The following is a description of a gene set: Using whole-genome Affymetrix microarrays (HG-U133A), we characterized the transcriptome profile of cultured human macrophages stimulated for 4 h with interleukin 1 (IL-1) or interleukin 6 (IL-6). We found that, in distinction to liver cells, IL-1 is much more potent than IL-6 in modifying macrophage gene expression, although considerable heterogeneity in response of macrophages deriving from individual blood donors was observed. The obtained results permitted to identify a large number of cytokine-responsive genes. coding for proteins of unknown function that are now being studied in our laboratory. They may represent novel targets in the anti-inflammatory therapy. Genes up-regulated in comparison of untreated macrophages versus those treated with IL1 and IL6. species: Homo sapiens from publication Jura J, Wegrzyn P, Korostyński M, Guzik K, Oczko-Wojciechowska M, Jarzab M, Kowalska M, Piechota M, Przewłocki R, Koj A (PMID 18498781) Human Gene Set: GSE8515_IL1_VS_IL6_4H_STIM_MAC_UP, and this is the list of marker genes: IGFBP3, TMEM268, TMC7, ZHX2, CFP, EN2, BID, SNN, TNIP1, PDE4B, ARL2BP, PPAT, MLH1, F2, MARCKSL1, SEPTIN6, RNF115, RFTN1, AGT, LARP4B, TOR3A, TNK1, CD80, MAU2, SERPINB2 (serpin family B member 2), VAV1, PIM2, DOCK9, RNGTT, IK, MED7, TP53BP2, B4GALT6, TSSK2, CCSER2, DENND5A, SLC2A6, VPS4A, CXCL8, ASAP2, P2RY10, CD70, IL1B, PAFAH1B2, SEC61G, UTP14A, PKIG, EGR3, P2RX7, STAT4, MAGEB3, NPY4R, BCL10, GYS2, RENBP, KDM6B, CXCL2, RIPK2, ST3GAL4, SIK3, CCR7, ZNF586, NECAP2, PSEN1, STX11, CES1P1, ANGPTL3, JAG1, PPIF, CCT2, UXS1, PRPF3, HCAR3, SLC43A3, ZNHIT3, EZH2, ACE2 (angiotensin converting enzyme 2), PLK3, RASGRP1 (RAS guanyl releasing protein 1), BTG2, SERPINB9, SINHCAF, TAS2R8, MAMLD1, SPAG1, TRAF1, BTG3, TNFAIP6, PTGER4, CCRL2 (C-C motif chemokine receptor like 2), TRAF3, CXCL3, SYNPO2L, ABHD17B, PHC3, FRZB, CDH13 (cadherin 13), SULT1B1, ICAM1, KANK1, WTAP, EDDM3B, CCL20, PRKCD (NCBI Gene Id 5580), TNFRSF4, PHLDA2, JUNB, MSC, RELB, PGAP1, CHST2, MAPKAPK5, SLC37A1, EHD1, SDC4, SEC22A, NFKB1, TRIP10, POU3F1, AMPD3, S100A3, MPHOSPH10, IER3, PPP1R10, NFKB2, TCF7L2, TNF, LPAR4, NFE2L1, KPNA2, PPP3CC, SLC16A6, FRY, RHBDF2, PLEK, ALAS1, GLOD4, PDCD5, ENTREP2, MDM2, BUD31, TET3, G0S2 (G0/G1 switch 2), IL21, YRDC, TKT, TENM1, SCAF8, GRAMD2B (GRAM domain containing 2B), BCL11A (NCBI Gene Id 55085), CDKL2, RAP2C, FKBP5, ASB6, SCARF1, CXCL6, LYRM4, RP2, CD83, MAP3K10, REL, BTG1, SPTBN4, TNFAIP3 (NCBI Gene Id 7128), CENPN, NUP62, IL6, NFKBIA, GPR25, RNASEH1, TRRAP, PPRC1, PIBF1, GPR171 (G protein-coupled receptor 171), TNFSF9, EBI3, WLS, ACSL1, ARHGAP22, PTX3, CCL4, KLF5, NCF2, ZNF250, APOO, BCL2L2, SLAMF7 (SLAM family member 7), NCK2, MAFF, MAP3K4, CXCL1, CA7, SLC35F5, ATF5, ZNF394, VOPP1, WNT5A, PTGS2, UTP25, LSS